Given this list of marker genes Zfp518a, Angptl2, Dag1, Smim13, Ubfd1, Nr3c2, Dip2c, Elovl7, Syt3, Hmbox1, Anxa7, Lmtk2, Tti2, C2cd2, Myocd, Ebf1, Cacna1d (calcium channel, voltage-dependent, L type, alpha 1D subunit), Stk35, Sntb2, Mbnl1, Srsf3, Acvr1b, Gsk3b, Wdr33, Topors, B3glct, Zfp654, Kif3b, Mtmr2, Slc8a1, Gulp1, Jakmip2, Lats2, Hoxa10, Vps37c, Nherf2, Rsbn1l, Prune2, Scn2a, Gria3, Mypop, Cplx2, Ccsap, Chsy1, Sptbn1, Pitpnc1, Kalrn, Slc25a5, Aplf, Sdcbp, Sirt1, Gpr21, Baz1a, Kdm1b, Erbb4, Kcnd1, Dpf1, Ilrun, Gabrb2, Ccdc92b, Rab1b, Jade1, Trim66, Ralgapb, Kctd1, Casz1, Ywhag, Bace1, Meltf, Atp8a1 (NCBI Gene Id 11980), Trpc6, Cpd, Ghsr, Ppp6r3, Clvs2, Shisa6, Slc30a4, Rock2, Sec14l1, Arhgap6, Entpd4, Taf4, Bach1, Bmper, Saysd1, 1600012H06Rik, Sema3a, Rnf43, Chmp4b, Zbtb34, Manea, Pdp1, Zfp385a, Wnt3, Bcl11a, Cdyl2, Zranb2, Zfp951, Arel1, Ntrk2, Mfhas1, Zfp236, Arhgef15, Ppp1r1c, Runx2, Pik3r2, Nampt, Kcnq5, Rspo2, Mob1b, Pggt1b, Pcyt1b, Ints2, Setbp1, Col5a1, Ubox5, Strbp, Zbtb44, Mtmr12, Slco5a1, Zdhhc6 (NCBI Gene Id 98138, zinc finger, DHHC domain containing 6), Ildr2, Kdm5b, Syne1, Nfxl1, Ppp1r12c, Dap, Meak7, Esrra, Zfp322a (NCBI Gene Id 218100, zinc finger protein 322A), Vamp2, Zfp385b, Abce1, Itm2b, Unc5c, Slfn5, Net1, Naaladl2, Thrb, Rbak (RB-associated KRAB zinc finger), D630045J12Rik, Hps5, Ado, Rrbp1, Sema3e, Fgf11, Cttnbp2, Med13, Rasal2, Lmbrd2, Fermt2, Elk3, Sv2b, Zfp831, Arhgef4, Foxo1, Cramp1, Slc5a7, Mapkbp1 (NCBI Gene Id 99332), Entpd7, Garin1b, Syt2 (synaptotagmin II), Mtss1, Nbea, Zcchc14, Slc16a6, Kcnb1, Creb5, Fbln5, Spock1, Slc24a2, Camk1g, Ndrg4, Cacna1e, Trp63, Bzw2, 4930562C15Rik, Ppp2r5c, Nedd9, Pde1a, Kcnj6, Tbc1d4, Kdm7a, Glrb, Parn, Jak2, Snx18, Actr3b, Psip1, Atp11b, Traf4, Bsn, Washc4, Ssr2, Rnf138, Rgl1, 2310022B05Rik, Slc9a9, Dram2, Phldb2, Setd7, Shisa7, Orc5, Cntnap1, Slc12a6, Gng7, Wscd2, Kcnn3, Smad5, Wdr45b, Pde8b (NCBI Gene Id 77611), Cadm3, Ergic2, Hmgxb3, Mastl, Mtus1, Man1a, Plekhb2, Col4a3, Elovl6, Wapl, Arhgap11a, Fcho2, Kcnab3, Ncln, Foxn3, Prlr, Ntng1, Hif1an, Chd1, Tstd2, Klf4, Zfp131, Arl5a, Tnpo1, Ssr1, Spmip4, Evi5 (NCBI Gene Id 231572), Edem3, Gad1, Zfp292, Cplx1, Atg14, Atp2b3, here is a description of the gene set: from publication Chen Y, Wang X (PMID 31504780) Genes predicted to be targets of miRBase v22 microRNA mmu_miR_135a_5p in miRDB v6.0 with MirTarget v4 prediction scores > 80 (high confidence targets). studied in species Mus musculus Mouse Gene Set: MIR_135A_5P